The following is a description of a gene set: Any process that modulates the frequency, rate or extent of endoplasmic reticulum tubular network organization. Mouse Gene Set: GOBP_REGULATION_OF_ENDOPLASMIC_RETICULUM_TUBULAR_NETWORK_ORGANIZATION studied in species Mus musculus, and this is the list of marker genes: Rab3gap1, Arl6ip1, Lnpk, Rab3gap2, Tmem33 (NCBI Gene Id 78493), Atl3